Given this list of marker genes TUBB2B, DNAH12 (dynein axonemal heavy chain 12), TUBB4B, TUBA1C, DNAH10, ACTR1B, TUBA1B, DNAI2, DNAH7, DNAL1, TUBB8, TUBB1, DCTN3, DCTN2, DCTN5, DNAL4, DNAH1, TUBB6, TUBB3, DCTN4, DNAH9, TUBB4A (tubulin beta 4A class IVa), TUBA1A, TUBA3E, TUBA3D, DNALI1, DCTN6, TUBB2A, DNAH2, DCTN1, ACTR10, DNAI1, DNAH3, TUBA8, TUBA3C, DNAH11, DNAH5, DNAH17, TUBA4A (tubulin alpha 4a), DNAH8, DNAH6, TUBB, ACTR1A, here is a description of the gene set: species: Homo sapiens Human Gene Set: KEGG_MEDICUS_REFERENCE_RETROGRADE_AXONAL_TRANSPORT Pathway Definition from KEGG: (DCTN+DNAH+DNAI+DNALI1+DNAL) == (TUBA+TUBB) Retrograde axonal transport. Pathway ID: N00976. Pathway type: Reference. Pathway class: nt06463 Parkinson disease.